Given this list of marker genes CRTAP, HSP90B1 (NCBI Gene Id 7184), PLD6, MVP, PARP14, LY75, AIRE, HCST, TMEM273, HYAL2, CD180, ORAI1, OR10A4, SEMA7A, CEACAM3, TYMP, KCNMA1, PRDX4, SMIM3, IGHD, ZNF485, B3GNT5, TNFSF13B, SAMSN1, IPO4, GNA15, PNO1, LTBP3, MPV17L2, SNX9, IFI35, ALG3, FAM174C, DUSP2, UBE2QL1, ACTC1, CRYM, LRRK2, DNAJC5B, SSR4, YIF1A, NOL6, SYTL4, DHRS9, MGAT5, TMEM109, MAST1, DHCR7, SLAMF1, HLA-DPB2, ITK (NCBI Gene Id 3702), PEMT, LRRC32, KIF25, GAMT, TRAF1, XCL1, ATXN1, IL19, CLN5, RAPSN, MAN2B1, TUB, TMEM205, LINC01013, KYNU, PMM2, JAM2, UNC119, MAPKAPK3 (NCBI Gene Id 7867), ICAM2, TNFRSF13C, FCRL5, ADAM8, CD164, SLCO5A1, NFKBIB, DNAJB5, PMEPA1, RCN3, MMP7, EMC10, TMEM41A, TP73, BATF, CD72, ZBED2, TMEM106A (NCBI Gene Id 728772), PTGS1, PCCB, HLA-E, GLDC, HLA-G, SPACA7, PUS3, SCARB2, NLE1, SLC39A14, MRGPRX1, NLRP8, NFKBIE, BTN2A2, BTN3A1, FCN1, BHLHE40, DGAT2, ICAM3, EBI3, VSIG1 (NCBI Gene Id 340547), SMAGP, CD320 (CD320 molecule), SLC27A4, VAV3, PLEKHG6, KCTD14, OR5E1P (olfactory receptor family 5 subfamily E member 1 pseudogene), BABAM2, TLCD1, AHSP, HCP5, EMILIN2, TAP1, HLA-J, MPEG1, TREH, CD83, ASPHD2, RGMB, AGMAT, CTSO, SIDT1, ZNRD2, KMO, PRR29, RPF2, TMEM182 (NCBI Gene Id 130827), BSG, SPPL2C, AMIGO2, PASK, IFI30, RASGRP1, BSND, HSD3B7, GTF3C2, IL12RB1, FCRLB, EHD3, SGPP2 (sphingosine-1-phosphate phosphatase 2), MGLL, SLC2A3, MIR155HG, SLC16A2, SUB1, TMT1A, ZDHHC24, TSPYL5, FCRL4, SYNGR3, ARC, BCL2A1 (NCBI Gene Id 597), HLA-DMA, METTL1, EGR2, GADD45G, MACC1, CXXC4, TM7SF2, SNX11, NEDD9, EGR3, ITGA5, IRF4, CYSLTR1, DNPEP, PIK3C2B, HLA-F, U2AF1L4, GPR137B, SRM, LGALS3, SCAMP3, MYD88, LINC00158, IL4I1, SCFD2, ATP4B, TMEM147, RNASET2, SLFN12, TRAF4, MXD4, CCR6, FCRL3, BTN3A3, TRAV12-2, ARSG, here is a description of the gene set: Human Gene Set: GSE21670_STAT3_KO_VS_WT_CD4_TCELL_UP studied in species Homo sapiens Genes up-regulated in CD4 T cells: STAT3 knockout versus wildtype. from publication Durant L, Watford WT, Ramos HL, Laurence A, Vahedi G, Wei L, Takahashi H, Sun HW, Kanno Y, Powrie F, O'Shea JJ (PMID 20493732) STAT3, an essential transcription factor with pleiotropic functions, plays critical roles in the pathogenesis of autoimmunity. Despite recent data linking STAT3 with inflammatory bowel disease, exactly how it contributes to chronic intestinal inflammation is not known. Using a T cell transfer model of colitis we found that STAT3 expression in T cells was essential for the induction of both colitis and systemic inflammation. STAT3 was critical in modulating the balance of T helper 17 (Th17) and regulatory T (Treg) cells, as well as in promoting CD4+ T cell proliferation. We used chromatin immunoprecipitation and massive parallel sequencing (ChIP-Seq) to define the genome-wide targets of STAT3 in CD4+ T cells. We found that STAT3 bound to multiple genes involved in Th17 cell differentiation, cell activation, proliferation and survival, regulating both expression and epigenetic modifications. Thus, STAT3 orchestrates multiple critical aspects of T cell function in inflammation and homeostasis.